The following is a description of a gene set: studied in species Mus musculus from publication Chen Y, Wang X (PMID 31504780) Genes predicted to be targets of miRBase v22 microRNA mmu_miR_18a_5p, mmu_miR_18b_5p in miRDB v6.0 with MirTarget v4 prediction scores > 80 (high confidence targets). Mouse Gene Set: MIR_18A_5P_MIR_18B_5P, and this is the list of marker genes: Alpl, Map3k3, Zbtb4, Sae1, Fndc11, Trim2, Ccn2, Add3, Zbtb44, Nfat5, Xylt2, Cdk19, Nr1h2 (nuclear receptor subfamily 1, group H, member 2), Tcaf2, Psd3, Pnisr, Zfp367, Slc12a6, Fryl, Ptgfrn, Fam136a, Map7d1, Ctdspl, Sox6 (SRY (sex determining region Y)-box 6), Ptgfr, Tmem100, Rhoj, Crebl2, Nacc1, Klf6, Kit, Rapgef4, Phc3 (polyhomeotic 3), Fchsd2, Mtmr2, Pias3, Serpinc1, Mapk4, Rexo2, Epb41l1, Triobp, Lypla1, Fgf1, Kdm5b, Eri1, Zbtb47, Nedd9, Rsu1, Tmem170b, Dusp16, Camsap2, Dock4, Smad2, Sorbs2, Zfp704, Kpna6, Ahcyl, Runx1, Map3k1, Sim2, Trappc10, Ino80d, Atxn1, Patj, Tshz3, Spata1, Kcnd3, Zfp961, Ptf1a, A630001G21Rik, Racgap1, Fbxo34, Esr1, Gpr37, Rora, Zfp62, Phf19, Atxn1l, Btg3, Glrb, Klhl20, Pex3 (NCBI Gene Id 80463), Smap2, Zfand5, Zfp451, Gigyf1, Hif1a, Dnajb4, Hmbox1, Smg7, Irf2, Cmtr2